The following is a description of a gene set: from publication Schaefer CF, Anthony K, Krupa S, Buchoff J, Day M, Hannay T, Buetow KH (PMID 18832364) Human Gene Set: PID_IGF1_PATHWAY studied in species Homo sapiens IGF1 pathway, and this is the list of marker genes: PRKCD, PRKCZ, GRB2, YWHAE, PXN, PRKD1, CRKL, HRAS, SOS1, IRS2, PTPN1, RPS6KB1, YWHAZ, PIK3CA, PDPK1, CRK, PIK3R1, AKT1, IGF1R, RACK1, IRS1, RAF1 (Raf-1 proto-oncogene, serine/threonine kinase), PTK2, GRB10, NCK2, BAD, PTPN11, BCAR1, SHC1